Given this list of marker genes Mdh2, Igf2, Dnmt1, H19, Ctla2a, Ldlr, Col9a1, Grb10, Pold1, Col11a1, Fzd8, Col6a2, Gas2, Efnb1, Gjb2, Jup, Crabp1, Col6a1, Hmgb1, Scd2, Peg3, U2af2, Cenpa, here is a description of the gene set: studied in species Mus musculus from publication Jackson-Grusby L, Beard C, Possemato R, Tudor M, Fambrough D, Csankovszki G, Dausman J, Lee P, Wilson C, Lander E, Jaenisch R (PMID 11137995) Genes down-regulated in MEF cells (embryonic fibroblast) upon Cre-lox knockout of DNMT1. Cytosine methylation of mammalian DNA is essential for the proper epigenetic regulation of gene expression and maintenance of genomic integrity. To define the mechanism through which demethylated cells die, and to establish a paradigm for identifying genes regulated by DNA methylation, we have generated mice with a conditional allele for the maintenance DNA methyltransferase gene Dnmt1. Cre-mediated deletion of Dnmt1 causes demethylation of cultured fibroblasts and a uniform p53-dependent cell death. Mutational inactivation of Trp53 partially rescues the demethylated fibroblasts for up to five population doublings in culture. Oligonucleotide microarray analysis showed that up to 10% of genes are aberrantly expressed in demethylated fibroblasts. Our results demonstrate that loss of Dnmt1 causes cell-type-specific changes in gene expression that impinge on several pathways, including expression of imprinted genes, cell-cycle control, growth factor/receptor signal transduction and mobilization of retroelements. Mouse Gene Set: JACKSON_DNMT1_TARGETS_DN